Given this list of marker genes CACNG5, CACNA1I, CACNA1C, CACNA1S, CACNA1E, CACNB3, CACNA1F, CACNG2, CACNA1D, CACNA1G, CACNA2D1, CACNB1, CACNA2D3, CACNG3, CACNB4, CACNA1A, CACNA1B (NCBI Gene Id 774), CACNA2D2, CACNG6, CACNG4, CACNB2, CACNG7, CACNA1H, CACNG1, CACNA2D4, here is a description of the gene set: Human Gene Set: KEGG_MEDICUS_REFERENCE_CA2_ENTRY_VOLTAGE_GATED_CA2_CHANNEL Ca2+ entry, Voltage-gated Ca2+ channel. Pathway ID: N01637. Pathway type: Reference. Pathway class: nt06528 Calcium signaling. Pathway Definition from KEGG: Ca2+(extracellular) -- CAV -> Ca2+(cyto) species: Homo sapiens